The following is a description of a gene set: species: Homo sapiens Central opacification of the cornea Human Gene Set: HP_CENTRAL_OPACIFICATION_OF_THE_CORNEA Reduced transparency of the central portion of the corneal stroma., and this is the list of marker genes: PTPN22, VSX1, COL18A1, PTPN2, IL2RB, IL2RA, CD247, JAG1, NOD2, FOXE3, SLC4A4, FOXC1 (NCBI Gene Id 3666), PITX2, ANKRD55, OVOL2, PAX6, CYP1B1, TACSTD2, STAT4, GNAS, TGFBI